Given this list of marker genes CPEB1, CRKL, NBPF8, ARMCX6, TOP3A, RNF111, DPP8, ETV5, STAT5A, NBPF12, LINGO2, SLITRK6, CGGBP1, ZNF609, CEP85L, AGGF1, NBPF11, GATD3, COX11, LINC03042, KCNE1, NEDD4L, EPHA10, CPEB2, GCSAM, C1orf216, ZNF74, NR4A2, OSBPL7, NBPF20, OS9, NAA25, ABRACL, SZRD1, HGH1, SNN, PIK3CA, FOXQ1, ADAM10, ELAVL2, IL1RAP, KCNJ2, CNST, PLPPR5, SLC4A8, SLC6A11, SALL3 (spalt like transcription factor 3), ZNF608, SHROOM2, FGFR2, ERRFI1, PTPRG, NBPF15, SHC3, RAPGEF1, GPM6A, ATP10A, DTWD1, BTBD3, BCL6, HM13 (NCBI Gene Id 92622), CD177, CASP10, LPGAT1, NBPF3, CADPS2, PLN, ANGPT2, NBPF14, ZSWIM1, KPRP, EXD3, C10orf55, here is a description of the gene set: from publication Chen Y, Wang X (PMID 31504780) Genes predicted to be targets of miRBase v22 microRNA hsa-miR-6894-3p in miRDB v6.0 with MirTarget v4 prediction scores > 80 (high confidence targets). studied in species Homo sapiens Human Gene Set: MIR6894_3P